The following is a description of a gene set: Activated forms of Ras family members are prevalent in many cancers where Ras mutants transduce signals essential for transformation, angiogenesis, invasion and metastasis. As a cancer progression model, we used NIH3T3 cells to explore the mechanism of Ras-induced tumorigenesis. Ras family mutants H-RasV12 and Rit79L strongly induced foci formation, while Rho family mutants RhoA-QL, Rac1-QL and Cdc42-QL were less effective. A comparison of downstream transcriptional targets of Ras and Rho family members using a 26 383 element cDNA microarray revealed that the osteopontin (OPN) gene exhibited the best correlation between magnitude of gene expression change and level of foci formation (r=0.96, P<0.001). In association with H-RasV12- and Rit79L-mediated transformation, foci secreted OPN protein and upregulated the OPN receptor CD44, suggesting the novel initiation of an aberrant OPN-CD44-Rac autocrine pathway. In support of this were the following observations. First, RGD-deficient OPN protein-binding activity was present in H-RasV12-transformed cells but not in control cells, and binding activity was inhibited by the CD44 blocking antibody. Second, foci formation, cell invasion and Rac activity were induced by H-RasV12 and inhibited by the CD44 blocking antibody. Third, foci formation by H-RasV12 was substantially reduced by a short interfering RNA (siRNA) specifically targeting OPN expression for knockdown. Fourth, H-RasV12-mediated transformation was not blocked by the GRGDS peptide, suggesting that OPN effects were not mediated by the integrins. Lastly, OPN knockdown affected the downstream expression of 160 '2nd tier' genes, and at least a subset of these genes appears to be involved in transformation. Indeed, four genes were selected for knockdown, each resulting in a disruption of foci formation and/or invasion. These results underscore the role of aberrant autocrine signaling and transcriptional networking during tumorigenesis. studied in species Mus musculus Cluster 3: genes whose up-regulation peaked 3 days after knockdown of OPN by RNAi in the NIH3T3 cells (fibroblasts) transformed by activated HRAS. Human Gene Set: TERAMOTO_OPN_TARGETS_CLUSTER_3 from publication Teramoto H, Castellone MD, Malek RL, Letwin N, Frank B, Gutkind JS, Lee NH (PMID 15516973), and this is the list of marker genes: GPR137C, TRAM2, PEG10, RBM7, PAGR1, SEC22C, NIP7